The following is a description of a gene set: A multiprotein subcomplex of the GATOR complex that regulates TORC1 signaling by interacting with the Rag GTPase. In human, this complex consists of WDR24, WDR59, MIOS, SEH1L, and SEC13. In S. cerevisiae, this complex is referred to as SEACAT and contains the Sea2p, Sea3p, Sea4p, Seh1p, Sec13p proteins. Human Gene Set: GOCC_GATOR2_COMPLEX species: Homo sapiens, and this is the list of marker genes: SEC13, WDR24, MIOS (NCBI Gene Id 54468), CASTOR1, CASTOR2, SESN3, SESN1, WDR59, SZT2, SEH1L